The following is a description of a gene set: Human Gene Set: GSE2770_IL12_ACT_VS_ACT_CD4_TCELL_6H_DN Genes down-regulated in CD4 T cells activated by anti-CD3 and anti-CD28: IL-12 (6h) versus untreated (6h). from publication Lund R, Aittokallio T, Nevalainen O, Lahesmaa R (PMID 14607935) Th1 and Th2 cells arise from a common precursor cell in response to triggering through the TCR and cytokine receptors for IL-12 or IL-4. This leads to activation of complex signaling pathways, which are not known in detail. Disturbances in the balance between type 1 and type 2 responses can lead to certain immune-mediated diseases. Thus, it is important to understand how Th1 and Th2 cells are generated. To clarify the mechanisms as to how IL-12 and IL-4 induce Th1 and Th2 differentiation and how TGF-beta can inhibit this process, we have used oligonucleotide arrays to examine the early polarization of Th1 and Th2 cells in the presence and absence of TGF-beta after 0, 2, 6 and 48 hours of polarization. species: Homo sapiens, and this is the list of marker genes: PLGRKT, IL2RG, TPH2, MED19, SPMIP1, CENPO, GPR52, ZFP36L2, MAGEC2, FAM124A, TMEFF1, YES1, VASH2, NFYB, ARID4B, CCSAP, ZNF852 (zinc finger protein 852), TDRD10, NUDT21, C14orf132, DTX3L, KMT2E, ARID5B, SNX31, ASB3, PAK3, PCNA, LUC7L2, TMEM123, MRTFB, PECAM1, LYPD6, COL9A2 (collagen type IX alpha 2 chain), GCH1, KRT38, CNPY4 (NCBI Gene Id 245812), PRICKLE2, CRISP1, CD3G, PLK4, MAF, FSTL1 (follistatin like 1), RIC8B, TRMT5, WDR43, PARG, PLPPR5-AS1, MPP7, CGN, LRIG2, USP32, N4BP2, ZNF224, SERINC5, SLC26A9, SNORD8, PHC3, PHF21B, B3GLCT, LINC00997, GBP6, SPAG16, CDKN2AIPNL, ZNF550, SEMA3G, RHOU, ASF1A, CEP120, FTSJ1, HACD3, NRAV, SPRED1, DYNLT5, KASH5, RHOH, GOLGA7, SRF, ABCC6, KLHL42, SMURF2, MMP12, MTMR11, IBA57, OLFML3, ZEB1, MORF4L1, ZBTB24, BCL10, SLC44A5, HMGN2, SOCS6, AK7, PAX8-AS1, UBXN6, MBNL3, LUC7L, SS18L1, SPC24, XIRP1, MPHOSPH8, SLC35E2B, WRNIP1, PSMA3-AS1, SLC14A2, LYSMD1, SLC25A14, MUC4, MAU2, RMI1, GPC2, TMEM128 (transmembrane protein 128), DYRK1A, HAUS3, LAMA3, MIR4453HG, SELENOW, CEP78, COL9A3, XIAP, STAT1, CHEK1, PTBP2, LPP-AS2, NUP62CL, ARSF, SUMO2, SLCO1C1, CYP3A7, SNORD89, CASD1, TMEM131, PLEKHF2, CCR9, FAM217B, TEK, TAPT1-AS1, ZNF468, TRIM37, MSI2, ADGRG6, SCCPDH, NRROS (NCBI Gene Id 375387), HNRNPK, CD6, HNRNPH1, EIF1AD, SYT14, BPTF, CXCL12, GID8 (GID complex subunit 8 homolog), FAM111A, G6PC2, IPO13 (NCBI Gene Id 9670), LZTS1, STAG1, CXCL2, ETV6, PGBD1, ANXA13, TCF12, H2AZ2, ANKRD20A11P, GPR137B, ELSPBP1, SHPRH, TXLNGY, SFR1, HOMER1, PRKCH, DCLRE1B, EPB41, KIDINS220, FBF1, GRB7, GPRASP1, DTX3, AMOTL2, SRPK2, NUP43, COA1, LBX2-AS1, FRG2EP, PTAFR, FANCF, STN1, DPP6, BEX4, CCDC168, AQP3, POLR1D, MFSD6, VEGFD